The following is a description of a gene set: The movement of a dendritic cell in response to an external stimulus. studied in species Homo sapiens Human Gene Set: GOBP_DENDRITIC_CELL_CHEMOTAXIS, and this is the list of marker genes: CCR5, CXCR4, CXCR1, LGALS9 (NCBI Gene Id 90793), TNFSF18, SLAMF8, CCL19, GAS6, GPR183, SPI1, CALR, CCL21, CCL5, IL12A, CXCR2, C1QBP, ARHGEF5, SLAMF1, PIK3CG, CCR2, TRPM4, CCR1, CCR6, CCR7 (NCBI Gene Id 1236), HMGB1, TRPM2